Given this list of marker genes STUB1, PTPN22, RCHY1, PRKN, RWDD3, TRIB3, HAMP, MAGEA2, SKP1, RPS2, UBE2C, UBE2V1, DDX3X, NOP53, INAVA, CDK5RAP3, FBXW7, PINK1, NDFIP2, HSPBP1, TOLLIP (toll interacting protein), PLK1, NMI, TNIP1, FBXO33, FBXO4, BIRC8, AIMP2, PEF1, NGF, MALT1, ARRDC4, CHFR, NPM1, CRY1, CDKN2A, NDFIP1, RASD2, NHLRC1, RASSF1, UBE3A, HDAC4, PELI1, DNAJA3, ARNT, DCUN1D2, CAV1, TICAM1, SAE1, CBLB, DNAJB2, RASSF5, RBX1, TSPYL5, SKP2, ZC3H12A, UBA2, SPHK1, UBE2L3, MAGEA2B, DCUN1D1, RNF111, SEPTIN4, BMI1, FAM107A, TANK, AXIN1, MARCHF7 (membrane associated ring-CH-type finger 7), MUL1, PIAS1, RNF180, MYCBP2, MAGEC2, RIPK2, PSMD10, SPSB4, SENP2, MTA1, TRAF6, LAPTM5, CUL3, CDC14B, UBE2V2, UBE2D1, BTRC, BCL10, WBP1L, BIRC3, DERL1, EGR1, PIAS4, CDC20, PRICKLE1, WFS1, DCUN1D3, FANCM, UBE2N, PIAS3, GABARAP, PTTG1IP, NSMCE3, NOD2, PAXIP1, TBC1D7, BIRC2, PHF23, KDM1A, VCP, CENPX, ARRDC3, UBB, DCUN1D4, PDCD6, FZR1, XIAP, HDAC3, MAPK9, AMER1, LRRK2, KLHL40, HSPA5, GNL3, ANGPT1, FANCI (NCBI Gene Id 751608), SPRTN, DCUN1D5, CENPS, COMMD1, GSK3B, UBE2S (NCBI Gene Id 27338), HUWE1, BIRC7, UBQLN1, GSK3A, here is a description of the gene set: Human Gene Set: GOBP_POSITIVE_REGULATION_OF_POST_TRANSLATIONAL_PROTEIN_MODIFICATION Any process that activates or increases the frequency, rate or extent of post-translational protein modification. studied in species Homo sapiens